The following is a description of a gene set: studied in species Mus musculus electronically inferred by orthology from the curated human pathway Reactome Pathway: LDL remodeling part of: Plasma lipoprotein remodeling This event has been computationally inferred from an event that has been demonstrated in another species.<p>The inference is based on the homology mapping from PANTHER. Briefly, reactions for which all involved PhysicalEntities (in input, output and catalyst) have a mapped orthologue/paralogue (for complexes at least 75% of components must have a mapping) are inferred to the other species., and this is the list of marker genes: P4hb